The following is a description of a gene set: The larger of the two subunits of a mitochondrial ribosome. Two sites on the ribosomal large subunit are involved in translation: the aminoacyl site (A site) and peptidyl site (P site). Human Gene Set: GOCC_MITOCHONDRIAL_LARGE_RIBOSOMAL_SUBUNIT studied in species Homo sapiens, and this is the list of marker genes: MRPL18, MRPL41, MRPL35, MRPL4, MRPL15, MRPS30, MRPL57, MRPL47, NSUN3, MRPL3, NSUN4, MRPL33, MRPL40, MRPL50, MRPL1, MRPL32, MRPL53, MRPL43, MRPL38, MRPL44, MRPL13, MRPL34, MRPL54, MRPL30, MRPL24, MRPL36, MRPL22, MRPL42, MRPL28, MRPL16, MRPL19, MRPL10, MRPL21 (mitochondrial ribosomal protein L21), MRPL14, MRPL45, MRPL2, MRPS18A, MRPL20, MRPL11, MRPL46, MRPL49, MRPL55, MRPL9, MRPL23, MRPL52, MRPL51, MRPL12, MRPL17, MRPL39, MRPL37, MRPL58, MRPL48, MTERF4, GADD45GIP1, MRPL27